The following is a description of a gene set: studied in species Mus musculus Catalytic activity that acts to modify a nucleic acid. Mouse Gene Set: GOMF_CATALYTIC_ACTIVITY_ACTING_ON_A_NUCLEIC_ACID, and this is the list of marker genes: Smarca4, Nipbl, Slfn3, Pusl1, Chd7, Eprs1, Chtf18, Mettl8, Dnmt1, Polr2h, Polrmt, Pan3, Skic2, Dna2, Cmtr2, Ern1 (NCBI Gene Id 97745), Trmt44, Tdrd9, Tet3, Pnpt1, Qtrt2, Polr3b, Fbh1, Fen1, Mettl16, Hltf, Yars1, Rfc4, Pif1, Dalrd3, Trmt10a, Trnt1, G3bp1, Msh5, Chd9, Nav2, Rnase9 (ribonuclease, RNase A family, 9 (non-active)), Crcp, Trmu, Ddx59, Mov10l1, Rtel1, Ptrh1, Nsun4, Fdxacb1, Mars2, Hmga1b, Ttf2, Tyw5, Dclre1a, Rps3, Apex1, Dis3, Tut4, Ang2, Rnase12, Sars2 (seryl-aminoacyl-tRNA synthetase 2), Nsun5, Endou, Ercc1, Tmt1a2, Tmt1a, Mettl15, Polr1a, Ftsj1, Tfb2m, Dhx35, Qtrt1, Ogg1, Thumpd3, Xrn2 (NCBI Gene Id 24128), Mcm8, Dhx9, Xrcc6, Wapl, Ddx5, Ung, Tmt1a3, Nudt16l2, Kars1, Rad1, Znfx1, Npm2 (NCBI Gene Id 328440), Polq, Rad51c, Cnot8, Eif4a2, Rnase2b, Cnot6l, Exo1, Trmt2a, Fars2, Ddx49, Rpp38, Rnase10, Hnrnpa1, Xrn1, Nsun3, Myg1, Polg, Ang6, Gatb, Ddx27 (DEAD box helicase 27), Rnmt, Chd6 (chromodomain helicase DNA binding protein 6), Aars2, Rad54l, Nsun6, Dus1l, Xrcc3, Ercc6l, Pop1, Gtf2f2, Pola1, Iars1, Helq, Pcna, B3gntl1, Rnase2a, Lig3, Mtfmt, Eif4a3l2 (eukaryotic translation initiation factor 4A3 like 2), Dnase2b, Rnh1, Rars1, Tep1, Rnase1, Ints11, Zc3h12a, Ago4, Slfn4, Snrnp200, Ddx4, Cwf19l1, Dcp2, Slfn8, Gars1 (glycyl-tRNA synthetase 1), Pde12, Dnmt3b, Dffa, Wrn, Smarca1, Rad54l2, Nob1, Ddx39a, Dnase1, Tmbim6, Alkbh4, Tert, Trub1 (NCBI Gene Id 98137), Polr2e, Dus4l, Aste1, Trex2, Trmt11, Tsen2, Trmt9b, Pold4, Recql5, Cars2, Lars2, Yars2, Top6bl, Tdg, Smarcal1, Alkbh2, Exosc10, Ptrh2, Tut1, Ddx6, Alkbh5, Polr2j, Ighmbp2, Dtd1, Rad51, Polr2c, Mrpl44, Pgbd5, Ercc6l2, Eri3, Mrm3, Rad17, Mlh1, Brip1, Dhx57, Trmt13, Chd2, Rad9a, Rev3l, Ptrhd1, Rfc2, Ear14, Rnasek, Cars1, Ddx54, Cdk5rap1, Pinx1, Henmt1, Recql4, Msh6, Rida, N6amt1, Dnase1l3 (NCBI Gene Id 13421), Dhx15, Pus10, Mcrs1 (NCBI Gene Id 97957), Arid1a, Wrnip1, Pold3, Rpp30, Tatdn1, Zc3h12d, Xrcc4, Spo11, Wars2, Gtdc1, Alkbh1, Dclre1c, Tut7, Zgrf1, Ruvbl2, Ggt1, Ang4, Tdg-ps, Nop2, Cnot6, Trmt1l, Smug1, Ear2, Hells, Ddx17, Chd4, Ftsj3, Poll (polymerase (DNA directed), lambda), Eme2, Neil1, Rlig1, Ddx19a, Slx1b, Endog, Cmtr1, Dhx16, Ddx10, Dtd2, Dhx40, Rnaset2a, Tsnax, Dntt, Xrcc2, Ddx52, Dtwd2, Terf1, Polb, Khnyn, Rpusd4 (NCBI Gene Id 71989), Sars1, D1Pas1 (DNA segment, Chr 1, Pasteur Institute 1), Mettl5, Ddx21, Cnot7, Mepce, Pop5, Zc3h12c, Tefm, Cdkal1, Prorsd1 (NCBI Gene Id 67939), Tyw3, Fancm, Thg1l, Chd3, Dffb, Meiob, Tyw1, Ddx24, Pot1a, Toe1, Rev1, Eri1, Ptges3, Supv3l1, Ang, Ddx43, Ddx46, Fbll1, Aptx, Trmt1, Mblac1, Mpg, Blm, Rnase6, Dicer1, Zranb3, Trmo (NCBI Gene Id 74753), Tfb1m, Msh2, Rcl1, Chtf8, Pus3, Gen1, Ercc3, Cnot1, Dynll1, Mus81, Ddx41, Gm28729, Dhx30, Ddx3y, Dmc1, Btaf1, Aarsd1, Ddx20, Hars2, Smarca2, Dkc1, Mcm3 (minichromosome maintenance complex component 3), Rtca, Pus7, Pld6, Polr3a, Marf1, Cecr2, Sub1, Dhx38, Neil3, Pola2, Mettl14, Ifih1, Tars1, Pan2, Hmces, Hars1, Nudt16, Rexo2, Alkbh3, Piwil2, Piwil1, Abce1, Dhx36, Polr3h, Bptf, Dars2, Bud23, Mbd4, Mcm6, Trmt61a, Myd88 (NCBI Gene Id 17874), Pole, Terc, Polr1b (polymerase (RNA) I polypeptide B), Rpp25, Mcm7, Rnase13, Vars1, Hmga2, Mre11a, Ago2, Mgme1, Ruvbl1, Ddx25, Polr2k, Polr2b, Ears2, Dtwd1, Slfn14, Usb1, Iars2, Dbr1, Trmt12, Eif4a1, Ern2, Eif4b, Shprh, Smarcad1, Ten1, Piwil4, Top2a, Sepsecs, Msh3, Chd1l, Fan1, Hmga1, Ear1, Recql (RecQ protein-like), Aqr, Dnmt3l, Smg6, Neil2, Ear6, Exd2, N4bp2, Eri2, Dis3l2, Eif4a3l1, Polm, Nudt12, Pld4, Ddx56, Bcdin3d, Dnase1l1, Drosha, Rnasel, Slu7, Polk, Chd8, Rbbp8, Elac1, Trdmt1, Noct, Lig4, Ascc3, Elac2, Mettl3, Tet1, Tgs1, Top3a, Cnot2, Helz, Helz2, Dscc1, Mrm1, Rnaset2b, Mettl6 (NCBI Gene Id 67011), Rad54b, Rag1, Eif4h, Polr1h, Mettl4 (NCBI Gene Id 76781), Mettl1, Pnldc1, Trmt10b, Tsr3, N4bp1, Zcchc4, Ptges3-ps, Mrpl58, Ddx55, Cdk7, Mau2, Lcmt2, Tars3, Dhx58, Xrcc5, Tdp1, Ddx19b, Slfn1, Mcm4 (NCBI Gene Id 17217), Cpsf3, Trub2, Nudt16l1, Dis3l (DIS3 like exosome 3'-5' exoribonuclease), Rfc5, Polr3k, Mov10, Pcif1 (NCBI Gene Id 70282), Rpp14, Polr2l, Anxa1, Pop4, Rad50, Acd, Isg20, Bivm, C1qbp, Pars2, Polr2i, Rad51b, Trmt2b, Ybey (NCBI Gene Id 68882), Rpp21, Vars2, Trex1, Mettl2, Aplf, Tdp2, Ddx11, Gatc, Ankle1, Rnaseh2a, Tet2, Exog, Qars1 (NCBI Gene Id 97541), Chd5, Lars1, Rnaseh1, Ddx51, Setmar, Tdrd12, Thumpd2, Dars1, Fmr1, Nars2, Ddx31, Farsa, Polr2f, Nsun2, Primpol, Dhx37, Slfn9, Xrcc1, Dus2, Prorp, Atrx, Ercc4, Chrac1, Top1mt, Alkbh8, Mcm2, Aen, Dnase1l2, Setx, Pus1, Rars2, Dimt1, Rngtt, Ptbp1, Rigi, Twnk, Tsen34, Polh, Dhx33, Polr2a, Trpt1, Dus3l, Tent4b, Ago3, Dhx29, Ddx1, Pold1, Ercc6, Ddx18, Pop7, Top1, Farsb, Mcm9, Nthl1, Apex2, Mtrex, Dhx32, Tarbp1, Top3b, Dhx8 (NCBI Gene Id 217207), Ercc2, Trit1, Mcm5, Terf2, Zc3h12b, Rnase4, Dhx34, Aars1, Rfc1, Polr1d, Fxr1, Polg2, Dnase2a, Endov, Qrsl1 (glutaminyl-tRNA synthase (glutamine-hydrolyzing)-like 1), Mars1, Dnmt3a, Fto, Ang5, Pms2, Isg20l2, Poln, Ercc5, Polr1c, Lactb2, Ankzf1, Prim1, Dqx1, Slfn2, Dxo, Top2b, Msh4, Dclre1b, Wars1, Ddx28, Ythdc2 (NCBI Gene Id 70219), Helb, Rtcb, Trmt10c, Ddx50, Snd1, Ggt5, Lig1, Poli, Etf1, Ino80, Ddx39b, Rpp40, Ddx3x, Upf1, Tars2, Parn, Pot1b, Trmt5, Chd1, Nars1, Atad5, Ddx47, Hfm1, Emg1, Jmjd6, Ep400, Rad51d, Ddx42, Trp53, Samhd1, Mrm2, Rfc3, Mutyh, Rbbp4, Nynrin, Pld3, Ear10, Rnase11, Smarca5, Eif4a3, Lrrc47, Fbl, Nme1, Pstk, Exo5, Eme1